The following is a description of a gene set: Human Gene Set: GOBP_NON_LYTIC_VIRAL_RELEASE The exit of a viral particle from a host cell that does not involve cell lysis. studied in species Homo sapiens, and this is the list of marker genes: CHMP2A, CHMP2B (charged multivesicular body protein 2B, NCBI Gene Id 7877), CHMP4BP1, CHMP4C, CHMP6, CHMP4B, VPS4B, CHMP3, CHMP1A, CHMP1B, CHMP7, ARL8B, CHMP5, CHMP4A, VPS4A